The following is a description of a gene set: part of: Downstream signaling of activated FGFR3 species: Homo sapiens The exact role of SHC1 in FGFR signaling remains unclear. Numerous studies have shown that the p46 and p52 isoforms of SHC1 are phosphorylated in response to FGF stimulation, but direct interaction with the receptor has not been demonstrated. Co-precipitation of p46 and p52 with the FGFR2 IIIc receptor has been reported, but this interaction is thought to be indirect, possibly mediated by SRC. Consistent with this, co-precipitation of SHC1 and FGFR1 IIIc is seen in mammalian cells expressing v-SRC. The p66 isoform of SHC1 has also been co-precipitated with FGFR3, but this occurs independently of receptor stimulation, and the p66 isoform not been shown to undergo FGF-dependent phosphorylation. SHC1 has been shown to associate with GRB2 and SOS1 in response to FGF stimulation, suggesting that the recruitment of SHC1 may contribute to activation of the MAPK cascade downstream of FGFR. Reactome Pathway: SHC-mediated cascade:FGFR3, and this is the list of marker genes: NRAS, FGF8, FGF23, HRAS, FGF18, FGF20, SHC1, FGF5, KRAS, FGF17, FGFR3, SOS1, FGF16, GRB2, FGF9, FGF2, FGF1, FGF4